Given this list of marker genes Pax6, Emx1, Nr2f1, Eomes, Tra2b, Emx2, Dmrta2, Adgrg1, Bhlhe22, here is a description of the gene set: The regionalization process that results in the creation of areas within the cerebral cortex that will direct the behavior of cell migration and differentiation as the cortex develops. Mouse Gene Set: GOBP_CEREBRAL_CORTEX_REGIONALIZATION studied in species Mus musculus